Given this list of marker genes LYN, PLAU, BIRC2 (NCBI Gene Id 329), LIF, TNFRSF9 (TNF receptor superfamily member 9), PAG1, IL7R, NFKBIZ, CMPK2, CXCL3, TRIM38, IFNL1, DNAJB6, NFKB1, LYPD3, SPRR2C, DAPP1 (dual adaptor of phosphotyrosine and 3-phosphoinositides 1), ZNF697 (NCBI Gene Id 90874), TMCC3, NFAT5, OAF, C1orf74, OCLNP1, TNFAIP6, DDIT4, IGFL1, CCNG2, SPSB1, TCIM, CCN3, IL4I1, TIAM2, LAMA2, IRF9, HBEGF, SPRR1A (NCBI Gene Id 6698), GBP3, TNFAIP8, FRMD4B, NFKBIA, TAP1, N4BP1, ZC3H12C, ARL14, LAMB3, CXCL1, IL15, NFKBIE, LACC1, ZC3H12A, INF2, SMAD3, RAB11FIP1, MAST4, SGPP2, BTG1, MAP2K3, BIRC3, IRAK2, MMP10, GPR132, SGK1, USP18 (ubiquitin specific peptidase 18), DDX52, NUAK2, EFNA1, PTX3, IFNGR1, STARD5, TNFRSF10B, PAOX, ICAM1, IFNGR2, IL1A, ITGB8, BCL3, SLC2A6, DNAJC3, SNX9, ANKRD22, TLE4, BTG2, TMEM171, BTN2A1, DSE, DUSP16, RIPK2, SEMA4C, MAFF, ARHGAP42, ERN1, TMEM265, CITED4, CXCL16, PPARD, BID, TUBB2A, B3GNT5, KDM7A, RIGI, OASL, MMP13, EDN1, NINJ1, TNIP2, IRF1, RTKN, SLCO3A1, CXCL10, BMP2, HIVEP1, RHOF, BAZ1A, TANK (TRAF family member associated NFKB activator), INHBA, IFIH1, IL36G (interleukin 36 gamma), RFX5, MARCKSL1, SERPINB9, NCOA7, IL32, ELOVL7, CSRNP2, CLDN1, SERPINB1, TNFSF10, FAM83B, EHD1, SLC7A2, CCL20, HERPUD1, OLR1, SDC4, RAB3IP, ZNFX1, KRT6B, PTAFR, GCH1, GCLC, SQSTM1, IL1RN, MXD1, PNRC1, B4GALT5, BCL2A1, SEMA7A, RELB, C15orf39, ISG20, NAV3, CHST15, GSAP, ABCA12, SLC52A3, CDKN1A, IL1B, STYK1, IRF6, NFKB2, NCK1, MFHAS1, CCL5, CEBPB, AMOTL2, C15orf48, DOCK4, CLN5, HDAC9, GRHL3 (grainyhead like transcription factor 3), ETS1, CYTH1, ABTB2, G0S2, TM4SF1, TAF4B, ATF3, TRAF1, SAMD4A, SPRR3, RNF19B, KLF6, ANKRD33B, TNFAIP3, GLS, ANKRD12, PLAUR, RASSF10, TLR2, CLIP4 (NCBI Gene Id 79745), KDM2A, PI3, HELZ2, TNIP1, SOCS3, CXCL2, DRAM1, CXCL8, C3orf52 (NCBI Gene Id 79669), NEDD4L, IFIT1, TRIM15, NUB1, SPRR2A, TNFRSF10D, HCAR3, IL23A, KYNU, PSEN1, PELI1, RWDD1, IL1R2, TNFAIP2, RAB24, SLFN5, CDC42EP4, CD83, ZNF165, CLDN18, GRAMD2B, LPAR6, IFIT3, RCAN1, here is a description of the gene set: Tumor necrosis factor alpha (TNFalpha) has been used to treat patients with certain tumor types. However, its antitumor activity has been undermined by the activation of IkappaBalpha kinase (IKK), which in turn activates nuclear factor-kappaB (NF-kappaB) to help cancer cells survive. Therefore, inhibition of TNFalpha-induced IKK activity with specific IKK inhibitor represents an attractive strategy to treat cancer patients. This study reveals IKI-1 as a potent small molecule inhibitor of IKKalpha and IKKbeta, which effectively blocked TNFalpha-mediated IKK activation and subsequent NF-kappaB activity. Using gene profiling analysis, we show that IKI-1 blocked most of the TNFalpha-mediated mRNA expression, including many genes that play important roles in cell survival. We further show that in vitro and in vivo combination of TNFalpha with IKI-1 had superior potency than either agent alone. This increased potency was due primarily to the increased apoptosis in the presence of both TNFalpha and IKI-1. Additionally, IKKbeta small interfering RNA transfected cells were more sensitive to the treatment of TNFalpha. The study suggests that the limited efficacy of TNFalpha in cancer treatment was due in part to the activation of NF-kappaB, allowing tumor cells to escape apoptosis. Therefore, the combination of IKI-1 with TNFalpha may improve the efficacy of TNFalpha for certain tumor types. Genes up-regulated in BxPC3 cells (pancreatic cancer) after treatment with TNF or IKI-1, an inhibitor of IkappaB kinase (IKK). from publication Zhang Y, Gavriil M, Lucas J, Mandiyan S, Follettie M, Diesl V, Sum FW, Powell D, Haney S, Abraham R, Arndt K (PMID 19010928) studied in species Homo sapiens Human Gene Set: ZHANG_RESPONSE_TO_IKK_INHIBITOR_AND_TNF_UP